Given this list of marker genes Cdc5lrt1, Magi3, Smg5, Akap6, Mtmr9, Jak1, Hmgcr, Ppp1r3f, Vrk3, Anapc7, Clec12b, Ankle2, Iqgap1, Sod1, Kat2a, Ensa, Gab2, Ctnnd1, Dlg2, Reg1, Ppp1r10, Git1, Traf3, Ppp1r3d, Kifap3, Adrb2, Hsp90aa1, Drd1, Ppp1r3g, Eif4ebp1, Ptpa, Strn4, Vcp, Smg7, Mvp, Ceacam1, Pik3r2, Fmr1, Phactr4, Pirb, Fcrl6, Styxl1, Dlg3, Pik3r1, Igbp1b, Gck, Pxn, Ppme1, Lgals3, Mapk8, Tbk1, Shc1, Ppp1cc, Akap5, Stau1, Skap1, Cacna1c, Ywhae, Vcan, Akt1, Irs2, Stat1, Adcy8, Smtnl1, Hsf4, Fas, Ptpn1, Igbp1, Pecam1, Grin3a, Insr (insulin receptor), Dab2ip, Hsp90b1, Dynlt4, Pawr, Bod1, Klre1, Ppp6r3, Sphk1, Ikbkb, Pdlim4, Itga1, Myo16, Ctnnb1, Mapt, Cacng8, Eif2ak3, Jak3, Ppp1ca, Fer, Lilrb4b, Akap11, Ppp1r3e, Cdc5lrt6, Nek2, Kif3a, Sirpa, Fcrl5, Rpa2, Strn3, Lmna, Ppp1r3a, Cdc5l (NCBI Gene Id 71702), Mastl, Mtmr4, Phactr1 (NCBI Gene Id 78746, phosphatase and actin regulator 1), Tmem225, Cd22, Ppp1r9b, Pabir1, Foxo1, Fbxl2, Cdc5lrt10, Cdc5lrt5, Cd33, Cdh2, Ppp6r1, Nptxr, Cadm4, Kcnn4, Met, Ppp2ca, Cfl1, Cdh5, Stat3, Mtmr3, Lck, Arpp19, Ppp1r9a, Shoc2, Rps6kb1 (NCBI Gene Id 72508), Pstpip1, Kcnq1, Ambra1, Pard3, Cdc5lrt4, Slc9a1, Vim, Map2k7, Mapk14, Slc6a3, Tprn, Gtf2f1, Traf2, Flt4, Grb2, Jup, Ppp3cb, Fcrl2, Lilrb4a, Ceacam2, Csf1r, Cttnbp2nl, Dlg4, Cdc5lrt8, Rack1, Ank1, Ppp1r11, Ppp6r2, Ppp1r3c, Akap1, Cdh1, Stat6, Cpd, Strn, Ppp2r2a, Bcl2, Anapc4, Mfhas1, Itpr1, Snx3, Csk, Stx17, Anapc5, Ap3b1, Cdc27, Pparg, Adissp (adipose secreted signaling protein), Cdc5lrt7, Map3k5, Bad, Cabin1, Ptk2, Cdc5lrt9, Ppp1r3b, Ghr, Cacna1b, Sh3rf2, Gna12, Egfr, Ppp1r15a, Clec12a, Atp2b4, Ros1, Trp53, Cdkn1b, Ptprt (NCBI Gene Id 19281), here is a description of the gene set: studied in species Mus musculus Mouse Gene Set: GOMF_PROTEIN_PHOSPHATASE_BINDING Binding to a protein phosphatase.